Given this list of marker genes Alox15, Ptgs2, Alox12, here is a description of the gene set: Reactome Pathway: Biosynthesis of DPAn-3 SPMs species: Mus musculus part of: Biosynthesis of DPA-derived SPMs electronically inferred by orthology from the curated human pathway This event has been computationally inferred from an event that has been demonstrated in another species.<p>The inference is based on the homology mapping from PANTHER. Briefly, reactions for which all involved PhysicalEntities (in input, output and catalyst) have a mapped orthologue/paralogue (for complexes at least 75% of components must have a mapping) are inferred to the other species.